Given this list of marker genes Jak2, Ifih1, Mapkapk2, Clec4a2, Abcc8, Mavs, Gpr18, Syt11, Lgals9, Cyba, Twist1, Clec7a, Ube2j1, Rad21, H2-T23, Ptpn11, Nod2, Arhgef2, Ccl4, Ccn1, Oas1b (2'-5' oligoadenylate synthetase 1B), Tlr5, Gstp3, Spn, Ptprj, Clu, Arrb2, Tlr4, Spon2 (NCBI Gene Id 76474), Lbp (NCBI Gene Id 16803), Ptpn6, Gstp-ps, Cactin, Havcr2 (NCBI Gene Id 268402), Ghsr, Ifngr1, Oas2, Oas1e, Oas1h, Ripk1, Lilrb4a, Ptger4, Ptprc, Ccl2, Tspo, Il27ra, Gpnmb, Oas1c, Cybb, Cd300ld, Zfp36, Tlr9, Angpt1, Ifng, Bpi, Fcgr2b, Cd24a (CD24a antigen), Arg2, Tyrobp, C1qtnf4, Hspb1, Tirap, Card9, Rasgrp1, Lilrb4b, Rigi, Cyp2j6 (cytochrome P450, family 2, subfamily j, polypeptide 6), Hsf1, Nr1h4, Il10, Pten, Oas1a, Cd47, Trem2, Fcer1g, Tlr3, Oas1d, Isl1, Il12b, Ptpn22, Fzd5, Cx3cr1, Tnfrsf1a, Cd209b, Hmgb1, Lpl, Ccr2, Il4, Ghrl, Psen2, Cidea, Psen1, Ccr5, Vsir, Ptafr, Azi2, Tlr2, Ccl3, Oas1f, Pomc, Ltf, Sash3, Trex1, Foxp1, Hdac2, Cd274, Zg16, Tgfb1, Tnfsf18, Lrrk2, Chrna7, Oas3, Sphk2, Arfgef2, Ly96, Ccl19, Oas1g, App, Cd36, Myd88, Akap12, Fcgr3, Clec4a3, Il1a, Il18, Il23a, Ncl, Zc3h12a, Nlrc3, Tnfrsf8, Selenok, Adam8, Errfi1, Csf1r, Stat3, Slamf9, Ticam1, Nfatc4, Nfkbil1, Sirpa, Acp5, Trim30a, Ccr7, Rara, Ilrun, Thbs1, Gstp1, Fcgr1, Wdr83, Tmem106a, Akap8, Arid5a, Ripk2, Il6, Hspd1, Gas6, Irak3, Mc1r (NCBI Gene Id 17199), Foxp3, Cd2, Syk, Wnt5a, Clec4a4, Bcl3, Cx3cl1, Lep, Fxr1, Zbtb20, Adam17, C5ar2 (NCBI Gene Id 319430), Tbc1d23, Sirt1, Il17f, Btk, Plcg2, Tnfaip3, Ager, Axl, Cd84, Mmp8, Twist2, Hdac3, Nod1, Cd14, Trim27, Slamf1, Tlr6, Fadd, Kcnn4, Gstcd (glutathione S-transferase, C-terminal domain containing), Ephb2, Tlr1, Setd4, Flt3, Gstp2, Dicer1, Mif, Frmd8, Elf4, Pycard, Mapk14, Dhx9, Lrrfip2, Pik3r1, Adipoq, Lilra5, Selenos, Il33, Il17a, Igf1, here is a description of the gene set: The appearance of any member of the TNF superfamily due to biosynthesis or secretion following a cellular stimulus, resulting in an increase in its intracellular or extracellular levels. Mouse Gene Set: GOBP_TUMOR_NECROSIS_FACTOR_SUPERFAMILY_CYTOKINE_PRODUCTION studied in species Mus musculus